The following is a description of a gene set: studied in species Mus musculus Mouse Gene Set: GOBP_2_OXOGLUTARATE_METABOLIC_PROCESS The chemical reactions and pathways involving oxoglutarate, the dianion of 2-oxoglutaric acid. It is a key constituent of the TCA cycle and a key intermediate in amino-acid metabolism., and this is the list of marker genes: Ogdh, Aadat (NCBI Gene Id 23923), Phyh, Col6a1, Idh2, Mrps36, Dld, Got1, Idh1, Dlst, Gpt2 (glutamic pyruvate transaminase (alanine aminotransferase) 2), Tat, Got2, Kyat3, Ogdhl